The following is a description of a gene set: studied in species Mus musculus Mouse Gene Set: GOBP_POSITIVE_REGULATION_OF_BLOOD_VESSEL_ENDOTHELIAL_CELL_PROLIFERATION_INVOLVED_IN_SPROUTING_ANGIOGENESIS Any process that activates or increases the frequency, rate or extent of blood vessel endothelial cell proliferation involved in sprouting angiogenesis., and this is the list of marker genes: Aplnr, Agtr1b, Vegfa, Agtr1a, Jcad, Gata2, Hmox1, Fgfbp1, Ppp1r16b, Apela